Given this list of marker genes TAF1L, BRDT, EP300 (NCBI Gene Id 2033), BRD4, ATAD2B, BRD9, PHIP, BRD7, BRD3, PSME4, BRD2, MLLT3, MLLT1, TRIM24, here is a description of the gene set: Human Gene Set: GOMF_ACETYLATION_DEPENDENT_PROTEIN_BINDING Binding to a protein upon acetylation of the target protein. species: Homo sapiens